Given this list of marker genes CHRNB2, CHRNA4, CHRM3, CHRND, CHRNA3, ACHE, CHRNB3, CHRNB1, CHRNA7, CHRNA1, here is a description of the gene set: Human Gene Set: GOMF_ACETYLCHOLINE_BINDING studied in species Homo sapiens Binding to acetylcholine, an acetic acid ester of the organic base choline that functions as a neurotransmitter, released at the synapses of parasympathetic nerves and at neuromuscular junctions.